The following is a description of a gene set: Human Gene Set: GOBP_POSITIVE_REGULATION_OF_DNA_DAMAGE_RESPONSE_SIGNAL_TRANSDUCTION_BY_P53_CLASS_MEDIATOR Any process that activates, maintains or increases the rate of the cascade of processes induced by the cell cycle regulator phosphoprotein p53, or an equivalent protein, in response to the detection of DNA damage. species: Homo sapiens, and this is the list of marker genes: ANKRD1, SPRED2 (sprouty related EVH1 domain containing 2), PYHIN1, ATM, ATR, PLA2R1, CDKN2A, ING4, ZNHIT1, EEF1E1, ZNF385A, RPL26, DDX5, MSX1, PMAIP1, HIC1, SPRED1